The following is a description of a gene set: This event has been computationally inferred from an event that has been demonstrated in another species.<p>The inference is based on the homology mapping from PANTHER. Briefly, reactions for which all involved PhysicalEntities (in input, output and catalyst) have a mapped orthologue/paralogue (for complexes at least 75% of components must have a mapping) are inferred to the other species. Reactome Pathway: Regulation of PTEN gene transcription part of: PTEN Regulation electronically inferred by orthology from the curated human pathway species: Mus musculus, and this is the list of marker genes: Scmh1, Phc1, Rbbp7, Rbbp4, Mbd3, Cbx2, Lamtor4, Bmi1, Rragc, Ezh2, Cbx6, Mta1, Sall4, Cbx4, Lamtor5, Ring1 (ring finger protein 1), Rheb, Rraga (Ras-related GTP binding A), Maf1, Cbx8, Lamtor1, Mta2, Lamtor2